Given this list of marker genes Fam161a, Rdh11, Crb1, Dram2, Myo3a, Ush1g, Gngt1, Inha, Reep6, Pcare, Opn1sw (NCBI Gene Id 12057), Rdh12, Pip4k2a, Whrn, Magi2, 2700049A03Rik, Epb41l5, Gnat1, Rs1, Dnm2, Eno2, Cerkl, Hspa8, Myo7a, Sag, Cep250, Nos1, Myo3b, Mak, Ush1c, Cib2, Cfap418, Bbs4, Atp1b2, Cdh23, Snap25, Ccdc66, Arr3, Phlpp2, Kif17, Rd3, Gnat2, Guca1b, Guk1, Sptbn2, Slc2a1, Rapgef4, Atp1a3, Rp1, Gnb1, Aipl1, Stx3, Prph2, Dnm3, Rcvrn, Ush2a, Zbed4, Asrgl1, Impg1, Bsg, Usp45, Adgrv1, Pdc, Dynlt1b, Hkdc1, Dnm1, Rho, Crocc, Kifap3, Shank2, Guca1a (NCBI Gene Id 14913), Tulp1, here is a description of the gene set: studied in species Mus musculus The inner segment of a vertebrate photoreceptor containing mitochondria, ribosomes and membranes where opsin molecules are assembled and passed to be part of the outer segment discs. Mouse Gene Set: GOCC_PHOTORECEPTOR_INNER_SEGMENT